Given this list of marker genes ZFP36L2, ID2, RETN, PAM, DDIT4, TGIF1, IFIT3, GHR, USE1, ARHGEF3, BTG1, TMEM106C, IFIH1, TMEM30B, EFNA1, CFD, SLC27A1, EFHD1, ARL4C, CXCR4, PKP2, LPL, EFNB2, SDC4, IFIT2, SCX, HMGA2, ADRA2C, IGHV3-43, WLS, PERP, GJB2, SCD, CD55, F3, CLDN5, IGLV2-18, PRSS23, PPP2R5A, ABCB1, SUPT4H1, TACSTD2, LIPE, ITGB4, PRXL2A, FAM107B, CES2, LTF, EPCAM, TEC, KRT18, SP4, PTPRR, IGKV1-27, MAP3K1, CRYL1, ME1, CCN2, NUPR1, C3, HLA-B, ADIPOQ (adiponectin, C1Q and collagen domain containing), CRIP2, DSP, BLNK, C16orf89, CAPG, DRAM2, NOP53, IGBP1, CDKN1C, IFI27L2, TNFRSF19, PRNP, MED24, CDH16, CA3, HTRA3, IGHG1, TPRG1L, here is a description of the gene set: Human infertility and recurrent pregnancy loss caused by implantation defects are poorly understood. Hoxa-10-deficient female mice have severe infertility and recurrent pregnancy loss due to defective uterine implantation. Gene expression profiling experiments reveal that Hoxa-10 is an important regulator of two critical events in implantation: stromal cell proliferation and local immunosuppression. At the time of implantation, Hoxa-10 mediates the progesterone-stimulated proliferation of uterine stromal cells. Hoxa-10 mutants express a stromal cell proliferation defect that is accompanied by quantitative or spatial alterations in the expression of two cyclin-dependent kinase inhibitor genes, p57 and p15. Hoxa-10 deficiency also leads to a severe local immunological disturbance, characterized by a polyclonal proliferation of T cells, that occurs in place of the normal progesterone-mediated immunosuppression in the periimplantation uterus. Genes co-regulated in uterus during a time course response to progesterone: SOM cluster 6. studied in species Mus musculus Human Gene Set: YAO_TEMPORAL_RESPONSE_TO_PROGESTERONE_CLUSTER_6 from publication Yao MW, Lim H, Schust DJ, Choe SE, Farago A, Ding Y, Michaud S, Church GM, Maas RL (PMID 12554760)